Given this list of marker genes PRLR, RELA, PRL, IL23R, CREBRF, here is a description of the gene set: The series of molecular signals initiated by the binding of the peptide hormone prolactin to its receptor on the surface of a target cell, and ending with the regulation of a downstream cellular process, e.g. transcription. Human Gene Set: GOBP_PROLACTIN_SIGNALING_PATHWAY studied in species Homo sapiens